Given this list of marker genes HEY1, HEY2, DLL4, NKX3-1, ACVRL1, RBPJ (NCBI Gene Id 51580), BMPR1A, ENG, NGFR, SRF, here is a description of the gene set: Human Gene Set: GOBP_DORSAL_AORTA_DEVELOPMENT species: Homo sapiens The progression of the dorsal aorta over time, from its initial formation to the mature structure. The dorsal aorta is a blood vessel in a single-pass circulatory system that carries oxygenated blood from the gills to the rest of the body. In a single-pass circulatory system blood passes once through the heart to supply the body once.